Given this list of marker genes MBD3, PRDM4, NEK7, IL3, CALM3, NANS, SF3A1, EFTUD2, BABAM2 (BRISC and BRCA1 A complex member 2), TMEM129, PPM1G, DPP9, SLC26A6, HEATR1, SLC7A11, PRPF31, PHLDA3, CILK1, XXYLT1, COMTD1, ADGRL1, SNRPD3, MSRB1, WDR12, EMC2, CCDC6, PWP2, RRP15, ZNF708, VRK1, TUBG2, RMDN3, BCKDK, MRPL21, RRAGB, RARS1, CENPS, FARP1, MIEF1, ANGPTL4, EEF1D, USP5, PCNP (PEST proteolytic signal containing nuclear protein), HEATR3, PLPP3, SPIN4, BOP1, GFOD1, PSME2, PNKD, HIBADH, PACRGL, PNN, SPATA24, DUS1L, IMMP2L, NEDD8, LRWD1, ECSIT, RAB1B, LDB3, UBAP2L, VCP, NELFE, PLEKHA8, KEAP1, GAN, MYBBP1A, PPP1R7, TMEM14C, NARS1 (NCBI Gene Id 9243), PIDD1, HARS1, FBXW11, TRAPPC3, INTS9, SLC30A3, RPP25 (ribonuclease P and MRP subunit p25), ECE1, NXPE3, SND1, IL2, NADK, DYNLT2B, PCK2, ITGB1BP1, KSR1, ADARB1, IMP3, CHID1 (chitinase domain containing 1), COX6B1, IMP4, ADIPOR2, TLCD3A (TLC domain containing 3A), BCS1L, NUCKS1, MIR103A2, NDUFS3, SLBP (stem-loop histone mRNA binding protein), COQ2, FANCB, SPRED1, OGFOD1, ERI1, SIRT4, IPO4, MPDU1, TRAPPC5, TRAP1, RAD18, ADO, PDCD5, CELF1, ADAMTS6, KLHL26, CHAC1, CHD1L, TRIM21 (NCBI Gene Id 6737), RBM43, SEPTIN7, HCCS, OXSR1, DGAT2 (NCBI Gene Id 84649), RFX5, NUDT21, AIMP1, PGAP2, GNAQ, POLR1H (RNA polymerase I subunit H), CACYBP, GLRX3, CCDC127 (coiled-coil domain containing 127), EIF5A, H4C3, FIGNL1, SLC39A8, GNG12, LRP8, SEC23B, BAG2, CDKN1A, PDXK, DNAJA3, RPN2, PPFIBP1, SLC12A4, RNF34, PA2G4, TUBGCP2, CPSF4, GYS1, SPAG7, FDFT1, PSMD11, PPRC1, CARS1, SPRYD4, ALDH9A1, MRPS12, HSPBP1, CDC37, TAF6, RNASEH2B, here is a description of the gene set: T cell differentiation to the Th17 effector subset requires stimulation through the T cell and co-stimulatory receptors, together with cytokine stimulation by TGFb and IL-6. The small molecule halofuginone (HF) inhibits Th17 cell development and induces a pattern of stress-regulated gene expression that mimics amino acid starvation. We used global transcript profiling to ask how halofuginone modulates gene expression induced during T cell activaiton and Th17 differentiation from publication Sundrud MS, Koralov SB, Feuerer M, Calado DP, Kozhaya AE, Rhule-Smith A, Lefebvre RE, Unutmaz D, Mazitschek R, Waldner H, Whitman M, Keller T, Rao A (PMID 19498172) Human Gene Set: GSE15624_CTRL_VS_6H_HALOFUGINONE_TREATED_CD4_TCELL_DN Genes down-regulated in CD4 T cells: control versus treated with halofuginone for 6h. species: Homo sapiens